The following is a description of a gene set: Human Gene Set: HP_DECREASED_FERTILITY studied in species Homo sapiens Decreased fertility, and this is the list of marker genes: HSF2BP, DAZ4, AMHR2, SPIDR, DNAAF4, TRIM32, RAD51, BRIP1, GATA4, IL17RD, BBS7, APOA1, DHX37, CEACAM3, PADI6, BNC1, NR3C1, CFAP70, AMH, HSD17B3 (NCBI Gene Id 3293), CCDC39, FSIP2, NPAP1, EDNRA, CT55, DNAH5, MEN1, CCDC146, CYLC1, HLA-DQA1, SSX1, PROP1, REC114, PALB2, PRKAR1A, HJV, CCNO, MAP2K1, DNAI2, GBA2, CCDC141, GCM2, DRC1, RPL10L, HMOX1, CDH23, DZIP1, DNAAF11, WDR11, FANCM, TTC12, POF1B, SCLT1, MOS, BLM, DCTN4, DNAAF5, CUL7, DNAH7, NEK10, TRIP13, DNAJB13, DNAH1, SOHLH1, ERCC4, PTPN11, DNAAF6, PANX1, BBS10, PWRN1, FEZF1, IQCN, SNRPN, BRCA2, SLC9A3, FBXO43, DNALI1, DAZ3, SNORD116-1, NME5, XRCC2, MAD2L2, IFT172, POU1F1, H6PD, NUP107, SPACA1 (sperm acrosome associated 1), HS6ST1, GNRHR, MPLKIP, SUN5, GCLC, SEMA3E, PPP2R3C, CDC20, FOXL2, ZP2, CFAP221, CDY1, CFAP298, CHRM3, POLR3H, ADGRG2 (adhesion G protein-coupled receptor G2), PROKR2, C2CD6, FIGLA, HESX1, ZFP36L2, CCIN, HERC2, NME8, PLCZ1, DUSP6, TACR3 (NCBI Gene Id 6870), DNAH8, DNAH11, FOXA2, TAF4B, NR0B1, RSPH9, AIP, FANCF, GALT, CEP290, ODAD3, SYCP3, SLX4, CYB5A, BRAF, MIF, STK36, KCNU1, ARMC2, RPS4Y2 (NCBI Gene Id 140032), SNORD115-1, DNAI1, NDN, BBS2, CCDC62, ACTL9 (NCBI Gene Id 284382), VCY, FANCL, CFAP44, TTC8, ACR, DNAH9, DNAH10, AR, ACTL7A, GLI2, CFAP74, MAGEL2, OCA2, IFT74, PNLDC1, CYP19A1, DHH, TSPY1, CFAP65, CFAP43 (cilia and flagella associated protein 43), RNF212, FGF17, CDY2A, CFAP47, NPHP1, NSD1, CFAP52, RAD51C, ZMYND15, GNRH1, CATIP, AKAP3, PLIN1, FANCI, SLC11A1, TERB1, FANCC, TEKT3, KASH5, MKRN3, LHX4, PNPLA6, ARL6, WDR19, AGPAT2, CATSPER2, CFTR, USP9Y, NDNF, CFAP418, WDPCP, ODAD1, OFD1, SLC6A14, SERPINA1, DNHD1, LMNA, CEACAM6, RBMY1A1 (RNA binding motif protein Y-linked family 1 member A1), SHOC1 (NCBI Gene Id 158401), FCGR2A, HSD3B2, DNAH17 (NCBI Gene Id 8632), SLC34A2, WEE2, MEI1, NLRP2, C14orf39, SCAPER, STX1A, FKBP6, BTG4, SPATA22, KCNN4, USP26, PGR, ODAD2, ZP3, FGF8, SOX10, LRRC23 (leucine rich repeat containing 23), BSCL2, BMP15, ANOS1, KPNA7, UBE2T, CEP112, STK33, NLRP5, LHCGR, PDE11A, FOXJ1, MOV10L1, CCDC34 (NCBI Gene Id 91057), DAZ2, IFT27 (NCBI Gene Id 11020), TDRD9, PSMC3IP (PSMC3 interacting protein), SEMA3A, PWAR1, AK7, RSPH4A, QRICH2, NANOS1, FLRT3, BBS4, PDHA2 (pyruvate dehydrogenase E1 subunit alpha 2), FGFR1, RNF216, BPY2, GNAS, LZTFL1, CFAP58, WRN, SYCP2L, DPY19L2, ZPBP (NCBI Gene Id 91091), SOX9, HYDIN, SLC26A8, ASTL, SPAG1, GGPS1, FANCA, AURKC, SPRY4, BRWD1, CATSPER1, GGN, DAZ1, ARMC12, GPR101, TOP6BL, SRY, RSPH3, CLDN2, ZSWIM7, DCC, CFAP251, CYP11A1, GAS2L2, HSFY1, XKRY (NCBI Gene Id 9082), BMP6, FANCE, DNAAF3, DNAAF2, OTX2 (orthodenticle homeobox 2), FANCB, AXL, BBS5 (NCBI Gene Id 428), PRLR (prolactin receptor), GSTM3, KDM5D, MNS1, TSGA10, CFAP61, MSH4, TEX15, TEX14, SEPTIN12, FSHR, NR5A1, MAP3K1, CCDC8, SYCE1, CTNS, TUBB8, BBS1, SDCCAG8, LRRC56, TERB2, SPEF2, WT1, CDC14A, CHEK1, SPATA16, FSHB, POR, DNAAF1, BBS12, CYP17A1, ODAD4, PATL2, KLHL10, BRDT, MCIDAS, RSPH1, MEIOB, PROK2, STAG3, BBS9, TGFB1, SIM1, MKS1, FANCG, PMFBP1, MRPS22, CFAP300, MSH5, ZP1, STRC, APC2, SYCP2, CCDC40, CHD7, SPINK2, TBX3, TTC29, TTC21A, SLC26A9, SRA1, HFE, DNAH2, DNAL1, OBSL1, BRCA1, ZMYND10, MKKS, CLCA4, M1AP, GCNA, VAMP7, STUB1, SRD5A2, SOX3, BBIP1, HLA-DQB1 (NCBI Gene Id 7924), ZFPM2 (zinc finger protein, FOG family member 2), RAF1, ALMS1, WWOX, TLE6, DDX3Y, FANCD2, RPGR, ATP7B, RFWD3, SPAG17, CEP19, TEX11